The following is a description of a gene set: The biological process whose specific outcome is the progression of the lung epithelium from an initial condition to its mature state. This process begins with the formation of lung epithelium and ends with the mature structure. The lung epithelium is the specialized epithelium that lines the inside of the lung. studied in species Homo sapiens Human Gene Set: GOBP_LUNG_EPITHELIUM_DEVELOPMENT, and this is the list of marker genes: IL13, CDC42, SHH, COL6A1, FGF10, AIMP2, YAP1, KRAS (NCBI Gene Id 3845), SAV1, THRA, WNT2, STRA6, LTA4H, RBPJ, BMP4, THRB, FGF7, KLF2, ADAMTSL2, FOXP2, SPDEF (NCBI Gene Id 25803), RCN3, SRSF6, ASCL1, NKX2-1, FOXA1, AGR2, RBBP9, PKD1, GRHL2, MAP2K1, GATA6, ERRFI1, FOSL2, HMGA2, FGFR2, WNT7B, HOXA5, CTNNB1, TMEM38B, MAP2K2, PPP3R1, IGF1, FOXJ1 (forkhead box J1), TP73, CREB1, SOX9, NFIB